The following is a description of a gene set: Human Gene Set: REACTOME_E2F_ENABLED_INHIBITION_OF_PRE_REPLICATION_COMPLEX_FORMATION species: Homo sapiens E2F-enabled inhibition of pre-replication complex formation, and this is the list of marker genes: CCNB1, ORC6, ORC4, ORC2, ORC5, ORC3, CDK1, ORC1, MCM8